Given this list of marker genes RCL1, TBL3, UTP20, NOP14, ABT1, NOP9, UTP23, FCF1, here is a description of the gene set: Endonucleolytic cleavage within the 5'-External Transcribed Spacer (ETS) of a tricistronic rRNA transcript that contains the Small Subunit (SSU) rRNA, the 5.8S rRNA, and the Large Subunit (LSU) rRNA in that order from 5' to 3' along the primary transcript. Endonucleolytic cleavage within the 5'-ETS of the pre-RNA is conserved as one of the early steps of rRNA processing in all eukaryotes, but the specific position of cleavage is variable. Human Gene Set: GOBP_ENDONUCLEOLYTIC_CLEAVAGE_IN_5_ETS_OF_TRICISTRONIC_RRNA_TRANSCRIPT_SSU_RRNA_5_8S_RRNA_LSU_RRNA species: Homo sapiens